Given this list of marker genes Slc12a3, Slc12a6, Slc12a2, Slc12a8, Slc12a1, Slc12a4, Slc12a5, Slc12a9, Slc12a7, here is a description of the gene set: Mouse Gene Set: GOMF_POTASSIUM_CHLORIDE_SYMPORTER_ACTIVITY Enables the transfer of a solute or solutes from one side of a membrane to the other according to the reaction: K+(out) + Cl-(out) = K+(in) + Cl-(in). studied in species Mus musculus